Given this list of marker genes PRR13, GCA, CCDC198, CHRND, SERPINB2, CTU1, PRKCE, EDN1, H6PD, ZFAND3, ADGRE1, ARL14EP, TMCO3, CPTP, SLAMF9, NCF4, STAT5A, BAIAP2, VEGFC, TSLP, ANXA1, KLF3, PAPSS1, TCF4, SEMA7A, CDKN2B, DNAJB6, ENG, PSMD12, CCR4, SLFN13, LAMP2, HSPH1, RNF19B, GDI1, ZBTB21, DUSP16, EEF1E1 (eukaryotic translation elongation factor 1 epsilon 1), SACM1L, SLC11A1, ENPP4, FAM53C, CREB1, OAS3, CAMSAP1, SERINC1, SLC7A8, PALS1, DNAJA1, SLC25A22, NOS2, PSMB10, IL15, NPPC, IL10, EBI3, MTF2, CCT3, BIRC3, UBE2M, RBM4, ZNF131, VCAN, PTGR3, RAB10, ZNF281, ZFAND2B (zinc finger AN1-type containing 2B), PARP12, TMEFF1, SOCS4, AGRN, DUSP2, TRMT1L, ACSL5, RHOQ, SOCS1, KAT2B, CCNG2, TNIP1, FST, TMCO6, GFI1, GOLGA3, GTPBP2, C18orf32, CCL5, SIKE1, ARID5B, GLIPR1, KMT5A, XYLT2, RFFL, TAP1, RASA4, COP1, NT5C3A, GABARAPL2, DENND5A (DENN domain containing 5A), ASF1A, AMPD3, MYF5, MTHFD2, CP, PDGFRB, F11R, PALLD, MEFV, CRTC2, MTHFS, PPP4R2, FCGR3A, RAB1A, ADAM17, TBC1D15, ZNF598, PPP2R2A, ANKRD24, BCL2L13, PTK2B (NCBI Gene Id 5748), IKBKB, TLR6, H2AC25, SPPL2A, PARP14, COL5A1, CHPT1, FAM8A1 (NCBI Gene Id 51439), SYNPO2, MKKS, NIBAN1, ADAMTS4, LIF, USP25, HOOK2, PHF23, SLAMF7, HSD17B11, ZNF346, MAPKAPK2, ZEB1, CMPK2, NUPR1, MARCHF5, SGCB, NCK1, EIF2S2, CLK1, SLC7A3, CASP1, RNF135, LY96, DPF2, VTI1A, KIF3C, PLA1A, CCDC71L, PTTG1, CRBN, PENK, RPS6KA2, DENR, TESK1, GRAMD1A, SLC38A2, POU2F2, PPIC, CPEB4, FBXW11, CD47, BCKDHB, NLGN2, TM9SF4, TJP1, AARS1, MAGOHB, PLA2G4A, SUOX, ZNF503, RDH10, NCK2, MITD1, LYRM1, DGCR8, ACP5, AGTRAP, CXCL11, ITPKB, KCTD1, ABCA1, NPY, RTP4 (receptor transporter protein 4), SLC25A37, INPP5B, TMEM39A, PCMT1, RSRP1, ARAP2, PTGR1, HAX1, here is a description of the gene set: species: Homo sapiens from publication Amit I, Garber M, Chevrier N, Leite AP, Donner Y, Eisenhaure T, Guttman M, Grenier JK, Li W, Zuk O, Schubert LA, Birditt B, Shay T, Goren A, Zhang X, Smith Z, Deering R, McDonald RC, Cabili M, Bernstein BE, Rinn JL, Meissner A, Root DE, Hacohen N, Regev A (PMID 19729616) Genes down-regulated in comparison of dendritic cells (DC) stimulated with CpG DNA (TLR9 agonist) at 0.5 h versus those stimulated with CpG DNA (TLR9 agonist) at 12 h. mouse primary BMDCs were stimulated with tlr ligands and gene expression changes were profiled on Affymetrix arrays Human Gene Set: GSE17721_0.5H_VS_12H_CPG_BMDC_DN